Given this list of marker genes ZNF195, ZNF426, PIK3CD (NCBI Gene Id 5293), CRYBG3, SLC24A3, RAB7A, ZNF559, NTNG1, SLF2, MYRF, RGMA, BCAM, M6PR, HSPA12A, BTRC, ZNF763, CLEC2D, RCSD1, PI4KA (NCBI Gene Id 5297), ZNF468, MGAT4B, WAPL, ACVR2B, GIT1, FLRT3, CACUL1, CLIP1, NCSTN, HAPLN1, TMEM220, SLC25A23, MGAT3, NUDT5, NFIL3, CELSR1, ZNF479, SMARCD1, PPFIBP1, ZNF776, TST, RFX3, PDE4D, ZNF559-ZNF177, PAN3, ZNF773, WDTC1, CCDC43, ANKRD23, ITGA3, SACS, GCNT2 (NCBI Gene Id 880), HSPA5 (NCBI Gene Id 3309), DENND6A, ARF6, PLEKHF2, SERPINE1, PLXNA2, SORCS3, CCDC88C, UBAP1, RBM47 (NCBI Gene Id 54502), BICC1, FAM222B, POU3F2, CYP51A1, HMCN1, ZNF418, MARCHF7, RALGAPA1, SOS2, SIRT1, ARRB2, CACNB2, ZNF544, RASSF2, PAXBP1, ATP13A2, DDR1, CELF2, MAP3K11, USPL1, IPO8, AUTS2, CCNJ, ZNF189, AGAP1, KDM3B (lysine demethylase 3B), ATXN7, ETS1, FZD4, KLHL29, NPAS2, GSK3B, PAX3, CECR2, TAB3, TMEM245, EIF5B, IL36B, NINL, RNF38, VPS26A, TUBG1, ZNF704, SULF1, PPARGC1A, ANK3, ITGA8, SHOC2, CCDC120, ZNF563, GPR89A, GPR63, NSG1, ZFP90, PDPN, RBPMS (NCBI Gene Id 11030, RNA binding protein, mRNA processing factor), CLCN3, ZNF516, ZNF584, TAFA2, PLXND1, BEND3, INO80D, ZNF440 (NCBI Gene Id 126070), GNG5, GPRC5A (NCBI Gene Id 9052), ARHGAP12 (Rho GTPase activating protein 12), RAD23B, ABCA1, ZNF439, ZNF589, ZFAND4, CDCA7L, TSPAN6, FER, CCNL1, ZNF329, TXNL1, NPY2R, KPNA4, NLK, ABHD17C, BLTP1, AKAP1, MARCHF8, GPR89B, FBXO4, TGFB2, ECE1, MICAL3, MAB21L1, TAF9B, HYCC2, ADD3, AFTPH, TPR, LXN, RNF11, ATG14, NAA40, SUN1, ZFYVE27, FZD6, ZBTB20, KL, P3H2 (NCBI Gene Id 55214), HIF1A, ZNF579, ARHGAP21 (NCBI Gene Id 57584), WDR76, CSDC2, MINDY3, CREBRF, RASSF3, CEP350, LIN7C, ASRGL1, USP31, AP1G1, here is a description of the gene set: species: Homo sapiens Human Gene Set: MIR199B_5P from publication Chen Y, Wang X (PMID 31504780) Genes predicted to be targets of miRBase v22 microRNA hsa-miR-199b-5p in miRDB v6.0 with MirTarget v4 prediction scores > 80 (high confidence targets).